The following is a description of a gene set: from publication Chen Y, Wang X (PMID 31504780) Human Gene Set: MIR4764_3P Genes predicted to be targets of miRBase v22 microRNA hsa-miR-4764-3p in miRDB v6.0 with MirTarget v4 prediction scores > 80 (high confidence targets). studied in species Homo sapiens, and this is the list of marker genes: HLA-DRB1, AKR1E2, MAD2L1, CAMK1G, ARNT, FGF9, PPP1R1C, CCDC112, OSBPL6, SNRPD1, JAZF1, ST8SIA5, FABP5, DACH2, SOX11, MAP3K1 (NCBI Gene Id 4214), FEM1C, NBEA, TC2N, NECTIN2, ANKRD44, CDK8, POU2F1, LRIG3, SPATA6, TIPRL, TNFRSF10A, KPNB1 (NCBI Gene Id 3837), DCC, TARS1 (threonyl-tRNA synthetase 1), PLAAT2, PCDHB14, LAMB1, TMEM135, PDK2, LAMTOR3 (late endosomal/lysosomal adaptor, MAPK and MTOR activator 3), IFI44L, ATXN7L1, GTPBP8, FAM171B, TBC1D1, PITPNM3, SNX24, NMT1, AAK1, SSPN, EXOSC3, RGS9BP, RNGTT, FUT9, ZNHIT3, KIAA0232, KITLG, RFWD3, PTPN13, BMP6, STAU2, RAP2A, ZNF546, USP10, FKBP3, KIAA0319, CYP1B1, PRAME (PRAME nuclear receptor transcriptional regulator), UNC5C, CAPRIN1, DNAJC21, C1orf141